The following is a description of a gene set: Mouse Gene Set: XU_CREBBP_TARGETS_UP species: Mus musculus from publication Xu W, Fukuyama T, Ney PA, Wang D, Rehg J, Boyd K, van Deursen JM, Brindle PK (PMID 16424387) Genes up-regulated in pro-B lymphocytes after knockout of CREBBP. CREB-binding protein (CBP) and its para-log p300 are transcriptional coactivators that physically or functionally interact with over 320 mammalian and viral proteins, including 36 that are essential for B cells in mice. CBP and p300 are generally considered limiting for transcription, yet their roles in adult cell lineages are largely unknown since homozygous null mutations in either gene or compound heterozygosity cause early embryonic lethality in mice. We tested the hypotheses that CBP and p300 are limiting and that each has unique properties in B cells, by using mice with Cre/LoxP conditional knockout alleles for CBP (CBP(flox)) and p300 (p300(flox)), which carry CD19(Cre) that initiates floxed gene recombination at the pro-B-cell stage. CD19(Cre)-mediated loss of CBP or p300 led to surprisingly modest deficits in B-cell numbers, whereas inactivation of both genes was not tolerated by peripheral B cells. There was a moderate decrease in B-cell receptor (BCR)-responsive gene expression in CBP or p300 homozygous null B cells, suggesting that CBP and p300 are essential for this signaling pathway that is crucial for B-cell homeostasis. These results indicate that individually CBP and p300 are partially limiting beyond the pro-B-cell stage and that other coactivators in B cells cannot replace their combined loss., and this is the list of marker genes: Hltf, Lgmn, Tha1, Gnl3, Adsl, Hmox1, Ppan, Gm33887 (NCBI Gene Id 105244034), Nme4, Rrp1b, Ctla2b, Mcm2, Prmt1, Ldaf1, Lmbr1l, Rad1, Gbp7, S100a6 (S100 calcium binding protein A6 (calcyclin)), Nvl, Lrrn1, Lrg1, Xpot, ENSMUSG00000139834, Prom1, Rcn1